Given this list of marker genes DCK, NT5C2, XDH, NT5C1A, GDA, NT5C, DNPH1, ADK, GUK1, PNP, ADA, DGUOK, here is a description of the gene set: Human Gene Set: GOBP_PURINE_DEOXYRIBONUCLEOSIDE_MONOPHOSPHATE_METABOLIC_PROCESS studied in species Homo sapiens The chemical reactions and pathways involving purine deoxyribonucleoside monophosphate, a compound consisting of a purine base linked to a deoxyribose sugar esterified with phosphate on the sugar.